The following is a description of a gene set: Reactome Pathway: Constitutive Signaling by NOTCH1 t(7;9)(NOTCH1:M1580_K2555) Translocation Mutant NOTCH1 t(7;9)(NOTCH1:M1580_K2555) mutant is expressed in a small subset of T-cell acute lymphoblastic leukemia (T-ALL) patients. This mutant protein results from a translocation that joins a portion of intron 24 of the NOTCH1 gene to the promoter sequence of T-cell receptor beta (TCRB), leading to overexpression of a truncated NOTCH1 protein in T-cells and their precursors. The truncated NOTCH1 contains amino acids 1580 to 2555 of the wild-type NOTCH1, lacking almost the entire extracellular domain, including EGF and LIN12 repeats. As EGF repeats are needed for NOTCH1 interaction with its ligands (DLL1, DLL4, JAG1, JAG2), the mutant NOTCH1 t(7;9)(NOTCH1:M1580_K2555) does not bind a ligand. The constitutive activity of NOTCH1 t(7;9)(NOTCH1:M1580_K2555) is based on its constitutive proteolytic processing into NOTCH1 intracellular domain (NICD1) by ADAM10/17 protease and gamma-secretase complex, as proteolytic cleavage sites are exposed in the absence of ligand binding in the mutant protein. Constitutively produced NICD1 accumulates in the nucleus, leading to aberrant activation of NOTCH1 target genes which play important roles in the development of T lymphocytes (Washburn et al. 1997. Radtke et al. 1999, Maillard et al. 2004, Sambandam et al. 2005, Tan et al. 2005). Infection of bone marrow cells with recombinant retroviruses that code for truncated NOTCH1 that resembles t(7;9)(NOTCH1:M1580_K2555) resulted in T-ALL-like illness in a portion of mice that received the infected bone-marrow transplant, with all tumors overexpressing truncated forms of NOTCH1. studied in species Homo sapiens part of: Signaling by NOTCH1 t(7;9)(NOTCH1:M1580_K2555) Translocation Mutant, and this is the list of marker genes: NOTCH1, JAG2, DLL4, ADAM10, JAG1, ADAM17, DLL1